Given this list of marker genes Ces1d, Msr1 (macrophage scavenger receptor 1), Ces1h, Ppard, Trem2, Ces1b, Ttc39b, Nr1h3, Ces1c, Apob, Ehd1, Pparg, Scarb1, Ces1g, Lpl, Srebf2, Cd36, Ces1f, Ces1e, Ppara, Ces1a, Ttc39d, Nr1h2, here is a description of the gene set: Any process that modulates the rate or extent of cholesterol storage. Cholesterol storage is the accumulation and maintenance in cells or tissues of cholesterol, cholest-5-en-3 beta-ol, the principal sterol of vertebrates and the precursor of many steroids, including bile acids and steroid hormones. Mouse Gene Set: GOBP_REGULATION_OF_CHOLESTEROL_STORAGE studied in species Mus musculus